The following is a description of a gene set: Human Gene Set: GOCC_AZUROPHIL_GRANULE Primary lysosomal granule readily stainable with a Romanowsky stain. studied in species Homo sapiens, and this is the list of marker genes: CREG1, TOLLIP, SURF4, ELANE, DPP7, PSAP, CEACAM6, LAMTOR1, TMEM179B, TMEM30A, DYNC1H1, PA2G4, PTGES2, GM2A, DDOST, PRSS2 (serine protease 2), FRK, MAPK1, ATP11B, PRTN3, NCSTN, VNN1, HEXA, FABP5, DNAJC5, DEFA1, VCP (valosin containing protein), CKAP4, ATP6V0C, PSMD1, SDCBP, NFAM1, MANBA, MGST1, CYB5R3, VAMP7, GCA, NPC2, RAB3D, ACTR2, ANXA11, PADI2, BST2, PRCP, HEBP2, RAB37 (NCBI Gene Id 326624), GAA, VAT1, ADA2, VAMP1, CMTM6, ANXA2, NHLRC3, RAP1B, SERPINB3, AZU1, FAF2, DEFA3, STOM, GLIPR1, SLCO4C1, VAMP8, ABCA13, VAPA, ARSB, HEXB, PYCARD, PRKCD, GNS, LPCAT1, CD63, RNASE2, ACLY, NDUFC2, NAPRT, GUSB, PIGR, CEACAM8, TUBB, STXBP2, TOM1, RAB5C (RAB5C, member RAS oncogene family), DNAJC13, TXNDC5, S100A7, LAMP2, SYNGR1, MNDA, TUBB4B, FTL, OLFM4, CPNE1, IST1, DSN1, RETN, PRDX6, TTR, ARHGAP45, HRNR, ARG1, CTSG, AGA, STK11IP, TRAPPC1, CTSC, HLA-H (NCBI Gene Id 3136), PRSS57, SNAP29, RAB44, LYZ, GLA, ATP8A1, LAMP1, SNAP23, RNASET2, CAP1, FUCA2, STX7, DEFA4, C6orf120, GDI2, MAGT1, GGH, UNC13D, FUCA1, C3AR1, CPPED1, BRI3 (NCBI Gene Id 25798), CD68, MPO, IMPDH1, ACP3 (acid phosphatase 3), FPR1, GRN, GLB1, BPI, ACTR10, CPNE3, DNAJC3, DEFA1B, STX3, PLAC8, IRAG2, ORM2, B4GALT1, RNASE3, SERPINA3, CCT8, ARL8A, PYGB, GALNS, CCT2, PSEN1, C3, MAN2B1, ARSA, CTSA